The following is a description of a gene set: Any process in which an organelle is transported to, and/or maintained in, a specific location. studied in species Homo sapiens Human Gene Set: GOBP_ORGANELLE_LOCALIZATION, and this is the list of marker genes: NDC80, NMD3, FMN2, SMPD3, SYNE3, DNM1L, APC, SPIRE1, ESYT1, DNM3, BICDL2, CHMP5, TRAPPC6A, CDCA8 (NCBI Gene Id 55143), CEP120, STXBP1, KIF2C, TRIP11, CEP83, NLGN2, CTNNB1, LAT, SLC18A2, PLEK, S100A13, GRP, CDCA5, BRSK2, VPS18, PEF1, TRIM46, NUP98, GJA1 (gap junction protein alpha 1), VAMP7, EXOC7, MLH1, TRAPPC2B, ATG14, GAB2, LLGL1, EIF6, APOLD1, VAMP8, PINK1, SUN2, BLOC1S4, RAB7A, LAT2, C17orf75, SPICE1, NEK2, CEP19, LIN7B, STX7, CHMP4BP1, DNM2, CLMN, UBB, EXOC4, TERB2, UBE2B, ARFGAP3, CHMP4B, MTM1, BLOC1S6, AP3B2, RPS15, FBXW11, IGHE, AURKC, PDZD11, CENPA, LRPPRC, SLC2A4, EML3, BECN1, KIF22, KLHL12, TRIM58, BORCS8, RAB17, PPFIA3, CLUH, NUP88, PLEKHM2 (pleckstrin homology and RUN domain containing M2), MYO1C, TMEM230, NEFH, CCDC186, BLOC1S3 (biogenesis of lysosomal organelles complex 1 subunit 3), MAP2K1, KIF5C, LAMTOR1, VAMP2, NTN1, BICD1, AP1G1, SPHK2, RAB24, ZW10, PPFIA2, NUSAP1, SLIT1, UNC13D, INPPL1, TRAPPC5, RIMS1, MFN2, CHMP6, SYNJ1, MAP4K2, NLGN1, MEF2A, SYT4, BICD2, F8A1, CDH2, SDAD1, MREG, FYCO1, CLASP1, EML4, XPO1, CENPQ, DCTN2, NUP62 (nucleoporin 62), KIF3A, GPSM2, ECT2, ARL8B, KXD1, CAV3, FAM83D, KAT2B, RMDN1, LLGL2, SPC25 (SPC25 component of NDC80 kinetochore complex), SAR1A, MYO1A, SYT1, MYH10, NRXN1, RNF167, CHMP2B, MAPRE1, SCN11A (sodium voltage-gated channel alpha subunit 11), CDK5, NSFL1C, ACTR2, EXOC5, MOS, RAB34, PIK3CG, EXOC1, KIFBP, CSNK1D, PTGDR, SPG11, OOEP, ANKFN1, TRAPPC4, PIP4P1, ABRAXAS2, AP1AR, GNAO1, NR4A3, UNC13A, STARD3, BIRC5, IFFO1, RACGAP1, SPC24, ARL6, STXBP3, TFG, PIK3CD (NCBI Gene Id 5293), POLR2M, TACC1, ASIP, SCRIB, RHOT1, RAN, HTT, CHMP1A, KIF28P, WIPI1, UNC13B (unc-13 homolog B), CDK1, RALB, ATP9A, BTK, RABGEF1, STX4, RAB6A, ATP2A1, CUL3, EXOC3, SEC16A, UCHL1, ARMC1, KIF25 (kinesin family member 25), KNSTRN, AP3D1, DTNBP1, KIF3B, IL13RA2, DEF8, ESYT3, VAPB, KIF5B, KIF13A, ATP13A2, CHMP7, NDEL1, TRAPPC9, LMNB1 (lamin B1), ATCAY, DAB1, HNRNPU, TRAPPC13, EZR, MYO19, MUL1, RASGRP1, KIF2B, SGO1, TOR1A, FCER1G, CHMP3, AP3S2, KIF1C, ZWINT, PEX14, ARMCX3, CBL, VTI1B, BRAT1, RIMS3, STX17, TESK1, CLNK (cytokine dependent hematopoietic cell linker), UNC13C, EPCIP (NCBI Gene Id 84761), KAT5, SHROOM2, MAPK15, STXBP2, MRGPRX2, CDC42, CENPE, ITGA4, BBS2, PTGDS, IFNG, EXOC8, TUBA1A, SYK, RAB11A, BRSK1, MAJIN, ATP2A2, ASPM, AURKB, KIF16B (NCBI Gene Id 79757), TACC2, PKHD1, USO1, SPAG9, GATA1, TSG101, RAB27A, CHMP4C, SNAP29, PCM1, MLPH, PEX13, HAP1, NAGLU, IRAG2, RAB3IP, CHMP1B, VPS4A, ZNF207, COPS5, CPLX2, DSN1, TMEM106B, GPR15LG, TRAPPC10, IL4R, AP3M1, MEIOC, KIFC2, SNF8, STARD3NL, BORCS7, RIMS2, MAP4, GEM, CDK5RAP2, BAIAP3, TSNARE1, RIOK2, FAM98A (NCBI Gene Id 25940), TLE6, PAX6, BLOC1S5, SNPH, BICDL1, PCDH17 (protocadherin 17), SKA3, BOD1, AP3M2, TRAPPC6B, CADPS2 (calcium dependent secretion activator 2), RAB8A, PSRC1, TACC3, MAP2, CAV2, PEX1, MGARP (NCBI Gene Id 84709), ACTR10 (NCBI Gene Id 55860), FGR, CDH3, STAM, FAM91A1, NUDC, WASL, PDPK1, ENKD1, YKT6, LMNB2, TANC2, SNAPIN, SLC4A5 (solute carrier family 4 member 5), KIF1A, SYTL4, NPM1, CCDC66, ESPL1, TSPAN9, SPAG5, VMP1, STX6, ADORA2B, PLK1, DYNC1I1, SKA2, AP3B1, RIPOR1, KASH5 (KASH domain containing 5), YWHAZ, WASF1, PIBF1, VPS33B, PRKN, BLOC1S1, IL13, MKKS, TRAPPC11, SIRT2, TTL, CFL1, SNX4, KIF5A, RABEPK, CD300A, SEPTIN5, BORCS6, STX16, FGF10, AGBL4, CALM1, SYN1, UBXN2B, F8A3, STX5, DYNLT1, STX3, MIS12 (MIS12 kinetochore complex component), DYNC1H1, STX1B, SEPTIN1, CTBP1, HPS6, TRAPPC2 (NCBI Gene Id 6399), RAB44, MSTO1, EXOC2, STK25, RAB11B, PINX1, KHDC3L, AHCYL1, TRAPPC12, STX8, KATNB1, CD84, LYN, PSEN2, SELENON, TRAPPC1 (trafficking protein particle complex subunit 1), VPS4B, TMEM201, WDR11, BORCS5, SPAST, TRAK1, AKAP9, SNAP25, RB1, RRS1, NECTIN2, MARK1, STX19, KNL1, PPP6C, MAPT, TMED9, INCENP, ACTR3, F8A2, PARD3B, STX2, AP1M2, FLCN, PLEKHM1 (pleckstrin homology and RUN domain containing M1), GRAMD2A, IKBKG, LRRK2, AP3S1 (adaptor related protein complex 3 subunit sigma 1), SYN3, KIF1B, UVRAG, MYO7A, KAT2A, PDZD8, GPR143, ITGB1, MARK2, CDR2L, CENPF, GATA2, SAR1B, SPIRE2, FNBP1L, BBS7, FEZ1, PREB, HOOK3, HSBP1, TRAPPC2L, LMNA, SDCBP, ESYT2, CHAMP1, MILR1, TBCCD1, LGALS9, MYO5A, BTBD8, KIF14, PCLO, BLOC1S2, MX2, LIN7A, CFTR, CDC23, GPSM1, OPA1, TEX14, LSG1, CDT1, ADGRE2, STX10, HDAC3, RNF13, PDCD6, SPRY1, MCPH1, NHERF1 (NHERF family PDZ scaffold protein 1), CHMP2A, ZWILCH, NUF2, STX11, ARCN1, CADPS, HIF1A (hypoxia inducible factor 1 subunit alpha), FOXF1, CCNB1, KLC2, SPO11, MAP1S, DNM1, CHGA, RCC2 (NCBI Gene Id 55920), KIFAP3, SNX6, MAD2L1, MFN1, PSEN1, SIRT1, CHMP4A, VPS11, RBM10, TPRG1L, BHLHA15 (NCBI Gene Id 168620), STX12 (syntaxin 12), PDCD6IP, ABRAXAS1, KIFC1, FERRY3, VAMP3, HGS (hepatocyte growth factor-regulated tyrosine kinase substrate), MISP, SYTL2, PKD1, LIMK2, RAB3A, SYNE2, TFEB, TMED10, CEP290, TBC1D23, KCNB1, SUN1, BCCIP, COPG1, TERF1, PMF1, VPS33A, BVES, RAC2, PARD3, AGTPBP1, TMED2, ZBED3, TLK2, MAP6, EXOC6, KIF18A, PAFAH1B1, MX1, VAPA, SAPCD2, NEFL, GBF1, STK11, KPNB1, LIN7C, UXT, NDE1, BUB3, MYH9, FCER1A, MAD1L1, SPOUT1, LAMP1, SPDL1, DOCK7, EXOC6B, DLGAP5, MDN1, PDCD10, STX1A, SYBU, NUMA1, RHOT2, NSL1, ARFGAP2, BSN (NCBI Gene Id 90068), KIT, SDC4, CENPC, SDC1, SYN2, TTK, TRAPPC3, SYT11, SPDYA, ACTN4, SKA1, ARHGAP21, COPG2, PLA2G3, CDK9, HDAC6, TPGS1, TERB1, PACS2, LTV1, DLG1, KNTC1, PLIN5, ANKRD53, MAP1B, RAB1A, CROCC, FES, CEP55, TRAPPC8, FHOD1, PTEN, NLRP5, BBS5, SEH1L, CLASP2, CLN3, SNCA, SYNDIG1, ATM, NDRG4, SNAP23, TCIRG1, NOP9, DCTN1, SPRY2, TRAK2